The following is a description of a gene set: studied in species Homo sapiens Human Gene Set: GOCC_CLUSTER_OF_ACTIN_BASED_CELL_PROJECTIONS A cell part consisting of multiple, closely packed actin-based cell projections., and this is the list of marker genes: MFSD10, LHFPL5, DCXR, SLC11A2, MYO1D, PRKCI, LCTL, FOLR1, EPS8L2, CYBRD1, SLC38A2, VIL1, ENPEP, ATP8B1, AQP8, SLC9A3, RDX, SLC20A2, CLIC1, SHANK2, FCHSD2, MYH9, MYO7B, STX4, PJVK, CORO2A, RAC1, CALB1, SLC4A7, ESPN, TWF2, VEZT, PLS1, HOMER2, ACE2, SI (NCBI Gene Id 6476), MME, SLC28A1, MORN4, AMN, DNM1L, SLC46A1, SLC15A1, ITLN1, MYO1E, FLII, ADGRV1, ABCG2, PKHD1L1, SLC26A6, IDO1, CA4, ANKS4B, ELMOD3, CLIC5, AQP1, MPP1, SLC28A3, TRPM6, WHRN, SLC2A2, B4GALT1, ANKRD24, SLC22A12, TRIOBP, EZR, GNA13, ESPNL, SLC22A5, TMC2, PAFAH1B1, ABCB1, USH2A, PIEZO2, ITPR3, CDHR5 (cadherin related family member 5), SLC5A6, MYO7A, PDZD7, GRXCR2, MYL12B, IFT20, FSCN2, CALB2, USH1C, SLC5A1, DRD5, MYH10, MYH14, STRCP1, TMC1, CDH23, RIPOR2, SLC7A11, SLC27A4, SCIN, CIB2, MYO3B, CLTRN, ACTN1, PLEC, SLC17A3, ADCY6, CLRN1, SLC34A3, SLC3A1, ACTB, SLC6A19, EPS8, MKKS, KPTN, KCNK1, NPPA, PEX19, ADD3, CD36, SLC28A2, TMPRSS15 (NCBI Gene Id 5651), DOCK4, LOXHD1, MYO1A, CDHR2, MYL6, ACTR3, MYO1C, CEACAM16, GRXCR1, RSPH9, SCART1, TPRN, LRP2, PDZK1, MYO3A, SLC26A4, STRC, DIAPH3, SLC26A3, SLC17A4, CLRN2, DCDC2, FLNB, CAPZB, KNCN, MINAR2, SOAT2, RHOC, VCL, PLB1, SNX5, HSP90AA1, PLD2, NHERF4, LIMA1, SLC6A18, MYO1B, PCDH15, SLC34A2, CAPZA2, RALGDS, CUBN, GNA12, MTTP, ACTN3, MYO15A, PIEZO1, TSPEAR, SLC34A1, CDC14A, BBS2, TRPA1, SLC19A1, ATP6V0A4, NHERF1, PTPRQ, SLC7A9